The following is a description of a gene set: species: Homo sapiens Human Gene Set: GOBP_REGULATION_OF_AUTOPHAGOSOME_ASSEMBLY Any process that modulates the frequency, rate or extent of autophagosome assembly., and this is the list of marker genes: MTM1, RALB, MTOR, TRIM32, FEZ1, SNX30, ATM, FEZ2, SNX7, MTMR3, PHF23, IFT20, PIP4K2B (phosphatidylinositol-5-phosphate 4-kinase type 2 beta), ELAPOR1, PIP4K2A, EHMT2, TBC1D12, WDR45, ATG2A, PIKFYVE, RAB3GAP2, NUPR1, SEC22B, UBQLN2, LRRK2, SCFD1, ULK1, PIP4K2C, RAB5A, LRSAM1, EFNB1, SNX4 (sorting nexin 4), CHEK2, BECN1, EPHB2, RAB3GAP1, MOAP1, TMEM39A, RNF186, SNX18, RAB1B, IFT88, WIPI1, TBC1D14, RNF5, SMCR8, C9orf72, SH3GLB1, PINK1